Given this list of marker genes EPX, HEATR6, DIP2B, FAF1, CDC42SE2, ECSIT, MS4A4A, ZYG11B, PPP3CA, NOM1, GMEB1, MANEA, BYSL, BTD, URB2, PTTG1IP, AZI2, ATP11B, MAPK14, THUMPD1, MEF2C, DYNC1I2, CAPZB, PTDSS1, FARSA, NELFB, DYNLL1 (dynein light chain LC8-type 1), MED22, SNAPC1, CENPC, AMMECR1L, LRRFIP1, C16orf54, RANBP2, VEZF1, SPG7, TSPAN14, NCL, NSDHL, MTSS1, SETDB2, STAG1, RFX3, SLC2A3, SLC39A10, ABCD1, ANTXR2, RAB12, TUFM, EHD3, TOLLIP, ZBTB7A, SLC30A4, DENND6A, ILF3, AP1M1, FPR1, SSB, RANBP9, ALDH3A2, LSM1, TAOK3, PHRF1, B3GALT6, PKHD1, CCR2, MOSMO, P2RY10, PSD3, PTAR1, TENT5A, LCLAT1, EREG, TOR3A, SYF2, DNM1L, RABIF, MAG, ANKRD11, TSG101 (NCBI Gene Id 89764), PPID, MRPL20, TXNDC5, MIR376B, PPA1, TMEM175, NCBP2, TGIF1, SPG21, ST7L, RETREG1, ASZ1, NKIRAS1, SOS2, AKR1B10, POLR1F (RNA polymerase I subunit F), EIF1B, ZMYND11, NME7, SAMD9L, CERS5, POLR1A, LRRC58, SEC16A, CDK2AP1, TUBB1, MED10, RBM28, MINDY1, CPM, TES, RAB22A, PPP2R5C, TMEM184C, TPD52, LAS1L, MOB4, ZBTB43, HHEX, PARP1, PIGU, GOLGA4, TXNDC15, TRAPPC4, DERA (deoxyribose-phosphate aldolase), DR1, CTSG, TMED8, DNAJC27, IMMP1L, TMEM39A, STARD7, EMC6, ZHX2, MYLIP, RAPGEF2, COMMD3, MED17, TMEM135, USP21, PPP4R3B, HIVEP2, IGHG3, CASP9, FUCA2, RALGPS2, CELF2, ARHGAP24 (NCBI Gene Id 83478), LAMTOR5, METTL8, THOC5, EHD4, CWC25, PFDN2, CTSO, C2orf49, TREML2, EXT2, PPP6R2, RNF144A, INTS10, THOC3, WDR45, here is a description of the gene set: from publication Dudziak D, Kamphorst AO, Heidkamp GF, Buchholz VR, Trumpfheller C, Yamazaki S, Cheong C, Liu K, Lee HW, Park CG, Steinman RM, Nussenzweig MC (PMID 17204652) Human Gene Set: GSE6259_FLT3L_INDUCED_DEC205_POS_DC_VS_CD4_TCELL_UP species: Homo sapiens Dendritic cells (DCs) process and present self and foreign antigens to induce tolerance or immunity. In vitro models suggest that induction of immunity is controlled by regulating the presentation of antigen, but little is known about how DCs control antigen presentation in vivo. To examine antigen processing and presentation in vivo we specifically targeted antigens to the two major subsets of DCs using chimeric monoclonal antibodies. Unlike CD8+ DCs that express the cell surface protein CD205, CD8- DCs, which are positive for the 33D1 antigen, are specialized for presentation on MHC class II. This difference in antigen processing is intrinsic to the DC subsets and associated with increased expression of proteins associated with MHC processing. Genes up-regulated in cells from Flt3L Melanom injected mice: splenic DEC205+ dendritic cells versus CD4 T cells.